Given this list of marker genes Ccdc39, Nphp3, Ccdc40, Zic3, Dnaaf1, here is a description of the gene set: Determination of the asymmetric location of the pancreas with respect to the left and right halves of the organism. Mouse Gene Set: GOBP_DETERMINATION_OF_PANCREATIC_LEFT_RIGHT_ASYMMETRY species: Mus musculus